The following is a description of a gene set: electronically inferred by orthology from the curated human pathway species: Mus musculus part of: Epigenetic regulation by WDR5-containing histone modifying complexes This event has been computationally inferred from an event that has been demonstrated in another species.<p>The inference is based on the homology mapping from PANTHER. Briefly, reactions for which all involved PhysicalEntities (in input, output and catalyst) have a mapped orthologue/paralogue (for complexes at least 75% of components must have a mapping) are inferred to the other species. Reactome Pathway: Formation of WDR5-containing histone-modifying complexes, and this is the list of marker genes: Kansl2, Kansl1, Phf20l1, Hcfc1, Men1, Tada2a, Kmt2b, Sgf29, Ash2l, Kdm6a, Hcfc2 (NCBI Gene Id 67933), Paxip1, Wdr82, Phf20, Setd1a